The following is a description of a gene set: Human Gene Set: GOMF_CALCIUM_DEPENDENT_PHOSPHOLIPASE_A2_ACTIVITY Catalysis of the reaction: phosphatidylcholine + H2O = 1-acylglycerophosphocholine + a carboxylate. This reaction requires Ca2+. studied in species Homo sapiens, and this is the list of marker genes: PLA2G2A, PLA2G2C, PLA2G4A, PLA2G2E, PLA2G4D (phospholipase A2 group IVD), PLA2G2D, PLA2G5, PLA2G10, PLA2G4F, PLA2G1B, PLA2G4B, PLA2G3, PLA2G4E, OC90, PLA2G12A, PLA2G4C (phospholipase A2 group IVC), PLA2G2F